Given this list of marker genes VAMP1, SLC18A3, CHAT, FARS2, MECP2, SNAP25, SLC25A1, SMC1A, COL13A1, NTNG1, SYT2, MYO9A, SLC25A20, SLC5A7, CHRNE, SLC39A8, GABBR2, AGRN, CDKL5, here is a description of the gene set: Human Gene Set: HP_SUDDEN_EPISODIC_APNEA studied in species Homo sapiens Sudden episodic apnea Recurrent bouts of sudden, severe apnea that may be life-threatening.